Given this list of marker genes Apoc3, Mylip, Ccdc22, Acsl3, Vldlr, Gpihbp1, Crp, Apoa5, Lpl, Pla2g12b, Trem2 (NCBI Gene Id 83433), Fech, Washc1, Dgat1, Arf1, Apoa2, Apob, Mpo, Apom, Lmf1, Abcg1, Ces1g, Lcat, Scarb1, Lipa, Csk, Pla2g5, Abca5 (NCBI Gene Id 217265), Plagl2, Ldlrap1, Khsrp, Soat1, Anxa2, Mfsd2a, Apoc2l, Lrpap1, Adipoq, Abcc8, Ehd1, Apoe, Pltp, Hnrnpk, Il19, Cd36, Pnliprp2, Cideb, Mttp, Lipc, Pla2g7, Pla2g10, Pnlip, Cnpy2, Nr1h4, Ldlr, Pcsk9, Ces1d, Lipg, Apoa1, Dgat2, Pnliprp1, Apoa4, Commd1, Nr1h2, Msr1, Soat2, Abca1, Pla2g2e (NCBI Gene Id 26970), Apoc2, Lpcat3, Gpld1, Abca7, Apoc1, Pla2g3, here is a description of the gene set: Mouse Gene Set: GOBP_REGULATION_OF_PLASMA_LIPOPROTEIN_PARTICLE_LEVELS studied in species Mus musculus Any process involved in the maintenance of internal levels of plasma lipoprotein particles within an organism.